Given this list of marker genes MAPK15, CENPJ, GPSM2, SPAG5, DYNC1H1, SASS6, NUMA1, STIL, here is a description of the gene set: Human Gene Set: GOBP_POSITIVE_REGULATION_OF_SPINDLE_ASSEMBLY species: Homo sapiens Any process that activates or increases the frequency, rate or extent of spindle assembly.